The following is a description of a gene set: Human Gene Set: GOCC_NUCLEAR_UBIQUITIN_LIGASE_COMPLEX studied in species Homo sapiens A ubiquitin ligase complex found in the nucleus., and this is the list of marker genes: ANAPC1 (NCBI Gene Id 64682), CBX7, ANAPC5, CDC20, ANAPC15, ANAPC7, CDC20B, BUB1B, CDC27, PHC2, BARD1, SAMD7, ANAPC16, ANAPC13, ANAPC11, RNF2, UBE2C, CUL7, CDC23, PHC3, PCGF2, PCGF3, CBX4, CDC16, PCGF6 (polycomb group ring finger 6), PCGF1, CDC26, BABAM2, ANAPC2, CBX2, ANAPC10, RAD51, RING1, BMI1, BRCA2, FZR1, PHC1, MAD2L2, BCOR, BRCA1, PCGF5, CBX8, BRCC3 (BRCA1/BRCA2-containing complex subunit 3), CBX6, SAMD11, UBE2S, ANAPC4